The following is a description of a gene set: Mouse Gene Set: GOMF_IGE_BINDING studied in species Mus musculus Binding to an immunoglobulin of the IgE isotype., and this is the list of marker genes: Fcer2a, Lgals3, Fcer1a, Ms4a2, Fcgr4, Fcer1g